Given this list of marker genes MED31, WDR37, TAF5, RAB11FIP4, PCBP1-AS1, ASAH1, WIPI2, KANSL2 (KAT8 regulatory NSL complex subunit 2), BTBD7, GRK2, HHEX, CORO1A, MTIF3, RIPK3, HERPUD2, ITGAE, F2RL1, RBM41, CETN3, FYB2, CDC40, TIGD1, DEPDC4, PEX2, RABGAP1L, GXYLT1, FAM8A1, TM9SF2, DCLRE1C, GRSF1, VRK3, DNAAF9, METTL18, ZNF791 (zinc finger protein 791), ST3GAL6, RBCK1, TLR1, WAC-AS1, CAP1, ASH1L, UBN1 (ubinuclein 1), CXorf38 (NCBI Gene Id 159013), ARPC1B, ANXA2R-AS1, COASY, FRAT2, APOM, TRIM23, RAC2, CSNK2A1, ADAMDEC1, ANKRD13D, RBM15B, ARL6IP5, RCN2, PTPRC, ING4, CEP76, ANAPC13, BCO1, CD300LF, FCGR3B, PP12613, CHPF2, KCNE3, PI4K2A (NCBI Gene Id 55361), EDEM3, CARD6, DCPS, TAF1D, CEP68, EMC8, CCR2, FES, CSF3R (NCBI Gene Id 1441), TMEM69, HIPK2, NOA1, SPTB, FBXO9, TXNDC9 (NCBI Gene Id 10190), ATP5F1E, ITPK1-AS1, ZNF281, CRLF3 (cytokine receptor like factor 3), RPL7L1, HCG27, FRAT1, CDC14B, MRPS22, BAZ2B-AS1, MRPL30, LYL1, HMGB1, KCTD10, GABPB1-AS1, CCDC69, SLC25A20, JKAMP, ABHD17B, POP7, CCDC85C, KIAA2013, FNTB, CEP19, PLAT, SUCNR1, POLD4, ZKSCAN4, ZNF701, ZNF180, TNFRSF10C, SCAP, OGFRL1, DHRS9, ISCA2, CTSZ, COQ8A, RRP36, SPEN-AS1, MACIR, GALNT1, MRPL41, RASSF2, TAT, GPR82, MAU2, BRI3BP, RGS19, JTB, MBNL1-AS1, FAM78A, PRKAB2, ZMYND15, SGCZ, DESI2, ERMARD, CD14, FA2H, RASSF1 (NCBI Gene Id 11186), GNAS, RPL32P3, SLC40A1, FBXW4P1, CDKN2AIP, MPZL3, SLC35E2B, ARHGAP9, DLGAP1-AS3, S100A6, SLC25A44, RNF130, ARHGAP25, CALM1, UTP15 (UTP15 small subunit processome component), RINT1, CCM2, LIAS, IRS2, TALDO1, LYSMD2, EVI2A, PDHB, PPP1R3D, TIGD3, TMEM59, ZNF319, CIRBP, WDR82, CPT2, CDKN2AIPNL, ASF1A, BPESC1, NR0B1, ENSG00000284948, ICAM3, PDCD6, C18orf21, PSMC1, SELL (NCBI Gene Id 6402), CISH (cytokine inducible SH2 containing protein), ZNF552, PTRH2, LBHD1, DNASE1, CACNA2D4, CCDC66, GLRX, ARPC2, RBM12B, ZNF302, PGLYRP1, RETREG3, IL31RA, DSTYK, here is a description of the gene set: We demonstrated recently that both constitutive and FAS-triggered apoptosis of human neutrophils are profoundly impaired by Francisella tularensis, but how this is achieved is largely unknown. To test the hypothesis that changes in neutrophil gene expression contribute to this phenotype, we used human oligonucleotide microarrays to identify differentially regulated genes in cells infected with F. tularensis strain LVS compared with uninfected controls. In order to examine the effect of F. tularensis on the neutrophil transcriptome, we performed microarray expression analysis on human neutrophils treated with F. tularensis subsp. holarctica live vaccine strain (LVS). Human Gene Set: GSE37416_CTRL_VS_3H_F_TULARENSIS_LVS_NEUTROPHIL_UP from publication Schwartz JT, Bandyopadhyay S, Kobayashi SD, McCracken J, Whitney AR, Deleo FR, Allen LA (PMID 22986450) Genes up-regulated in comparison of control polymorphonuclear leukocytes (PMN) at 3 h versus PMN treated with F. tularensis vaccine at 3 h. species: Homo sapiens